The following is a description of a gene set: Human Gene Set: KEGG_MEDICUS_REFERENCE_TRAPPI_RAB1_SIGNALING_PATHWAY species: Homo sapiens Pathway Definition from KEGG: TRAPPI -> RAB1 TRAPPI-RAB1 signaling pathway. Pathway ID: N01291. Pathway type: Reference. Pathway class: nt06125 Membrane trafficking (bacteria)., and this is the list of marker genes: TRAPPC6A, TRAPPC5, TRAPPC6B, TRAPPC1, TRAPPC3, RAB1B, TRAPPC4, RAB1A, TRAPPC2 (NCBI Gene Id 6399)